Given this list of marker genes Lgals3, Hck, Cd44, Fgfr2, Btg2 (NCBI Gene Id 98237), Tgfb1, Krt18, Pdgfa, Hbegf, Col1a2, Serpine1, Cdh1, Cdkn1a, Bex1, Tgfbr2, Cd38, Samd4, Fos, Icam1, Junb, Cdkn2b, Col4a2, Itgal, Vim, App, Afp, Col4a1, Egr1, Laptm5, Ucp2, Vcam1, Casp1, Cp, Itgav, Rbp1, Rai14, Tgm2, Igf2, Col1a1, Lgals1, Stat1, Cybb, Emp1, H19, Trp53, Sparc, Spp1, here is a description of the gene set: studied in species Mus musculus Retinoic acid-responsive genes up-regulated in hepatocellular carcinoma (HCC) samples of TRIM24 knockout mice. from publication Khetchoumian K, Teletin M, Tisserand J, Mark M, Herquel B, Ignat M, Zucman-Rossi J, Cammas F, Lerouge T, Thibault C, Metzger D, Chambon P, Losson R (PMID 18026104) Mouse Gene Set: KHETCHOUMIAN_TRIM24_TARGETS_UP Hepatocellular carcinoma (HCC) is a major cause of death worldwide. Here, we provide evidence that the ligand-dependent nuclear receptor co-regulator Trim24 (also known as Tif1alpha) functions in mice as a liver-specific tumor suppressor. In Trim24-null mice, hepatocytes fail to execute proper cell cycle withdrawal during the neonatal-to-adult transition and continue to cycle in adult livers, becoming prone to a continuum of cellular alterations that progress toward metastatic HCC. Using pharmacological approaches, we show that inhibition of retinoic acid signaling markedly reduces hepatocyte proliferation in Trim24-/- mice. We further show that deletion of a single retinoic acid receptor alpha (Rara) allele in a Trim24-null background suppresses HCC development and restores wild-type expression of retinoic acid-responsive genes in the liver, thus demonstrating that in this genetic background Rara expresses an oncogenic activity correlating with a dysregulation of the retinoic acid signaling pathway. Our results not only provide genetic evidence that Trim24 and Rara co-regulate hepatocarcinogenesis in an antagonistic manner but also suggest that aberrant activation of Rara is deleterious to liver homeostasis.